The following is a description of a gene set: This event has been computationally inferred from an event that has been demonstrated in another species.<p>The inference is based on the homology mapping from PANTHER. Briefly, reactions for which all involved PhysicalEntities (in input, output and catalyst) have a mapped orthologue/paralogue (for complexes at least 75% of components must have a mapping) are inferred to the other species. part of: p75NTR signals via NF-kB electronically inferred by orthology from the curated human pathway species: Mus musculus Reactome Pathway: p75NTR recruits signalling complexes, and this is the list of marker genes: Ubb, Sqstm1, Ikbkb, Irak1, Myd88 (myeloid differentiation primary response gene 88), Rps27a, Ngfr, Ngf